The following is a description of a gene set: from publication Chen Y, Wang X (PMID 31504780) Human Gene Set: MIR329_5P Genes predicted to be targets of miRBase v22 microRNA hsa-miR-329-5p in miRDB v6.0 with MirTarget v4 prediction scores > 80 (high confidence targets). species: Homo sapiens, and this is the list of marker genes: AEBP2, SERPING1, OPRM1, MTX3, C2CD2, DLX2, L1CAM, IRX2-DT, CELF4, AP1S2, PCM1, RAP1B, POMC, HIKESHI, SLITRK4, ESYT2, MDGA2, CTNS, NUDT21, MLLT6 (MLLT6, PHD finger containing), PLEKHA5, ZNF584, AKTIP, IQCK, SAMSN1, SLC16A4 (NCBI Gene Id 9122), SKA2, MTSS1, IRAK3, SRSF2, TMEM35B, RLN1, NDST3, EHD4, GRM3, MBNL2, RPL7L1, MARCHF6, LRRC75A, ABCG4, FUCA2, SETD9, FGFR2, NTAN1 (N-terminal asparagine amidase), VPS29, CDK14, DIRC1, GPM6B, RAB10, G2E3, SCPEP1, SHROOM3, GPATCH1, DENND1B, SNX19, MAFB, MAPK8, SEC24A, HOPX, MTF1, PMP22, CASD1, REPS2, CREG2, SRSF8, MIB1, GLRX, ZNF746, ZBBX, PCNX1, ACTB, VSTM4 (V-set and transmembrane domain containing 4), RND1, CTBS, ABHD17B, EML4, SPINK8, ZNF189, GREM1, TMEM106B, LRRTM2, ZNF354C, SHPRH, PABPC4L, TMEFF2, CILK1, RBMS3 (NCBI Gene Id 27303), CEP68, ZNF480, SLC46A2, PAPOLG, NECTIN3, ZNF681, SGK1, CYP3A5, POLB, KLHL31 (NCBI Gene Id 401265), DPY19L2, FXN, FUBP3, CASP10, CRNN, ARID2, DUS4L, ATMIN, PWWP2A, SYNJ2BP (synaptojanin 2 binding protein), LSAMP, ALDH3A2, TNRC6B (trinucleotide repeat containing adaptor 6B), WDR73, FOXD4L3, NECAB1, UNKL, ZNF17 (NCBI Gene Id 7565), NOCT, SELENOF, MIP, LAMP2, SAMTOR, NAA15, RSL1D1, THAP12, ENAH, FOXD4L6, ZNF300, STAG2, COL8A2, SGPP1, MOSPD1 (NCBI Gene Id 56180), TOGARAM1, NUP35, CPEB3, RMND5A, NUP50, C17orf50, PTRH2, CDC14B, SYT16, CAP2, MEIOC (NCBI Gene Id 284071), HAX1, IL6ST, AIRIM, ZCCHC3, ZNF37A, RCHY1, GRM5